The following is a description of a gene set: Mouse Gene Set: GOBP_CELL_CELL_ADHESION_MEDIATED_BY_INTEGRIN The attachment of one cell to another cell via an integrin, a heterodimeric adhesion receptor formed by the non-covalent association of particular alpha and beta subunits. studied in species Mus musculus, and this is the list of marker genes: Itgb1, Cd24a, Wnk1, Adam9, Ccl5 (C-C motif chemokine ligand 5), Dpp4, Swap70, Cxcl13, L1cam, Plpp3, Vcam1, Ada, Piezo1, Itga5, Fermt3, Podxl, Skap1, Cd3e, Itga4, Npnt